Given this list of marker genes Babam1, H2ac25, H2ac23, H2ac24, H2ac7, Brca1, H2ac1, Mysm1, Stam, Ep300, H2ac11, H2ac10 (NCBI Gene Id 319173), H2ac19, H2ac12, H2ac15, H2ac22, H2ac4, Nlrp3, H2ac20, Bard1, H2ac6, Rps27a, Ubb, Brcc3, H2ac8 (NCBI Gene Id 319166), H2ac13, here is a description of the gene set: electronically inferred by orthology from the curated human pathway This event has been computationally inferred from an event that has been demonstrated in another species.<p>The inference is based on the homology mapping from PANTHER. Briefly, reactions for which all involved PhysicalEntities (in input, output and catalyst) have a mapped orthologue/paralogue (for complexes at least 75% of components must have a mapping) are inferred to the other species. studied in species Mus musculus part of: Deubiquitination Reactome Pathway: Metalloprotease DUBs